Given this list of marker genes SERPINB7, EGR1, MYC, LIN28A, ITGB3, FLCN, IL6R, GATA3, BMP7, PDGFA, PDGFD, CFLAR, BMP4, MIR125A, WT1 (WT1 transcription factor), PDGFB, here is a description of the gene set: studied in species Homo sapiens Any process that modulates the frequency, rate or extent of cell proliferation involved in kidney development. Human Gene Set: GOBP_REGULATION_OF_CELL_PROLIFERATION_INVOLVED_IN_KIDNEY_DEVELOPMENT